Given this list of marker genes Enox1, Lta4h, Wdr59, Chsy1, Sys1, Dennd6a, Nexmif, Plp1, Il22ra2, Rimklb, Tmem174, Prkca, P2ry12, Colq, Msl1, Irf2bpl, Nol4, Cdk19, Tle4, Ccr2, Dpp8, Rbm27, Strn3, Aldh6a1, Cpeb4, Lcp1, Plagl2, Map1b, Rab2a, Cks1brt, Fbxl5, Sstr3, Dll1, Eif3a, Chrna9, here is a description of the gene set: Mouse Gene Set: MIR_362_5P_MIR_500_5P species: Mus musculus from publication Chen Y, Wang X (PMID 31504780) Genes predicted to be targets of miRBase v22 microRNA mmu_miR_362_5p, mmu_miR_500_5p in miRDB v6.0 with MirTarget v4 prediction scores > 80 (high confidence targets).